Given this list of marker genes Cnnm1, Kcna1, Cnnm2, Edn3, Slc41a1, Pth, Trpm7, Tmem94, Hoxa3, Pthlh, Ank3, Enpp1, Cnnm3, Trmt10a (NCBI Gene Id 73171), Kel, Xk, Mtss1, Cnnm4, Gcm2 (NCBI Gene Id 56639), here is a description of the gene set: studied in species Mus musculus Mouse Gene Set: GOBP_MAGNESIUM_ION_HOMEOSTASIS Any process involved in the maintenance of an internal steady state of magnesium ions within an organism or cell.